Given this list of marker genes BMPR1A, ACVRL1, HEY2, SRF, RBPJ, ENG, DLL4, HEY1 (hes related family bHLH transcription factor with YRPW motif 1), here is a description of the gene set: The process in which the anatomical structures of the dorsal aorta are generated and organized. The dorsal aorta is a blood vessel in a single-pass circulatory system that carries oxygenated blood from the gills to the rest of the body. In a single-pass circulatory system blood passes once through the heart to supply the body once. Human Gene Set: GOBP_DORSAL_AORTA_MORPHOGENESIS studied in species Homo sapiens